Given this list of marker genes SLC45A2, DCT, TYRP1, OCA2, TYR, here is a description of the gene set: species: Homo sapiens Melanin biosynthesis takes place in specialized cells called melanocytes, within membrane-bound organelles referred to as melanosomes. Melanosomes are transferred via dendrites to surrounding keratinocytes. Keratinocytes and melanocytes are collectively known as 'the epidermal melanin unit'. Each melanocyte is in contact with approximately 40 keratinocytes in the basal and suprabasal layers. Melanocytes are distributed in the epidermis, hair follicles, the inner ear and the eye. <br><br>Melanocytes in mammals and birds produce two chemically distinct types of melanin, black to brown eumelanin and yellow to reddish-brown pheomelanin (Ito & Wakamatsu 2008, Simon et al. 2009, d'Ischia et al. 2013). These differ in their responses to UV radiation; eumelanin has the ability to convert absorbed light energy into heat energy (Meredith & Riesz 2004) and to detoxify reactive oxygen species (ROS), while pheomelanin is a phototoxic pro-oxidant. Most natural melanin pigments contain eumelanin and pheomelanin (Ito & Wakamatsu 2003) and are termed 'mixed' melanins. Neuromelanins are mixed melanin-like pigments which are mainly found in neurons of the substantia nigra and locus coeruleus. Synthesis of NM may prevent the accumulation of toxic catechol derivatives. NM can sequester a variety of potentially damaging molecules such as beta-carbolines, heavy metal ions and 1-methyl-4-phenylpyridinium (MPP+), a drug which causes Parkinson's Disease-like symptoms. Models suggest that mixed melanogenesis occurs in three stages. The initial stage of melanin biosynthesis is the production of cysteinyldopas, which continues while sufficient cysteine is available. The second stage is the oxidation of cysteinyldopas to produce pheomelanin, which continues while cysteinyldopa concentration is sufficiently high. The last stage is the production of eumelanin, which begins when cysteinyldopas and cysteine are depleted. The ratio of eumelanin to pheomelanin is determined by tyrosinase activity and the availability of tyrosine and cysteine. part of: Metabolism of amino acids and derivatives Reactome Pathway: Melanin biosynthesis